The following is a description of a gene set: The chemical reactions and pathways resulting in the formation of an isoprenoid compound, isoprene (2-methylbuta-1,3-diene) or compounds containing or derived from linked isoprene (3-methyl-2-butenylene) residues. species: Homo sapiens Human Gene Set: GOBP_ISOPRENOID_BIOSYNTHETIC_PROCESS, and this is the list of marker genes: LSS, PDSS1, AKR1C3, MVK, CYP1A1, GGPS1, PDSS2, DHDDS, FDPS, NUS1, COQ2, ALDH1A3, RPE65, IDI2, BCO1, HMGCS1, ALDH1A2, DHRSX, PRMT3, CRPPA (NCBI Gene Id 730683), DHRS9, PMVK, HMGCR, ALDH8A1, RDH10, HMGCS2, MVD, SRD5A3, RBP1, IDI1